Given this list of marker genes TSHZ2, MAP3K3, COL1A2, NPM3, MMP2, PTPN2, ULBP1, MEF2D, LIMD2, B3GALT2, ZNF654, RNF114, PER2, SCARF1, CERS6, AZIN2, RNF185, MED31, CRNKL1, LPAR1, IL17RE, RPL22, MAGED1, ARL1, CAMLG, NREP, UNC5C, EGLN3, SRPX2, THEM6, SLPI, TNFAIP2, NPEPPS, PCNX1, NCAM1, RASGRP2, REV1, ORM1, COL1A1, KRT79, PPP1R15A, LRMDA, CALB2, DNAJC4, CELA2A, FAM222B, ZFP37, TRIP10, CNIH2, CGGBP1, COL4A1, APOC2, SNCA, AQP9, IL12A, TEAD1, TMEM119, OASL, RIMKLA, FAM241B, ZCRB1, SRGAP1, P4HA2, COQ8A, TGFBI, GBP4, SDF4, SLC15A3, MRPL44, COL5A1, RPE, SLC2A3, OSM, RNF182, MMP9, SHISA9, ACHE, CPED1, BEX2, RNASET2, MAGED2 (MAGE family member D2), DDT, BRINP1, RBPJ, ERO1A, DDO, SAPCD2, SAA4, CRLF1, RO60, CSF3, CSF2, LRRIQ3, AMTN, BMAL2, UBL5 (NCBI Gene Id 59286), FYB1, CAMK2N1, ZBTB8OS, TMEM130, PPFIA3, RNF125, ANKRD37, CFAP210, SERPINE1, ATRNL1, KCNK10, ZFP36L1 (NCBI Gene Id 677), DTNA, ZNF264 (zinc finger protein 264), BAMBI, TBC1D12, KDM5B, MCFD2, DKK2, QPCT, FAM162A, WHAMM, SLCO1C1, ALDH1L2, NFKBIZ, RPS25, ZC3H18, RTRAF, CXCL6, H2AJ (H2A.J histone), PDPR, ADAM9, SRRM2, LUM, ZMIZ1, CH25H, ANKRD12, SMOX, VEGFA, NTAN1, CFP, HDAC9, HP, TNFSF14, C11orf71, AMMECR1L (AMMECR1 like), CLHC1, DCN, MAN1A1, FKBP7, MTDH, SCN4B, G3BP2, VPS36, LETM1, OMP, ERRFI1, ERGIC1, TNIP1, TMC7, SNAP29, COL23A1, ATP9A, SKIL, SLC27A4, EVC, AOAH, GREM2, FAM43A, LMF1, CEP44, PTGES, COX19, COL3A1, PRDM16-DT, TAOK3, IL4R, GYS1, SERPINB4, PPP1R1B, SLX4IP, DECR2, DMGDH, CD300LF, SLC1A2, DDIAS, ARPP19, CRCT1, PPBP, HEATR6, FCGR2B, PLBD1, CACNA1H, ANTXR1, LHCGR, PILRB, GCNT2, BST1, ECPAS, S100A8, SLC4A3, DNAJC12, PICALM, CX3CL1, here is a description of the gene set: studied in species Homo sapiens Genes down-regulated in CD8 T cells: healthy versus CLL (chronic lymphocytic leukemia). from publication Görgün G, Holderried TA, Zahrieh D, Neuberg D, Gribben JG (PMID 15965501) To examine the impact of tumors on the immune system, we compared global gene expression profiles of peripheral blood T cells from previously untreated patients with B cell chronic lymphocytic leukemia (CLL) with those from age-matched healthy donors. Although the cells analyzed were not part of the malignant clone, analysis revealed differentially expressed genes, mainly involved in cell differentiation in CD4 cells and defects in cytoskeleton formation, vesicle trafficking, and cytotoxicity in CD8 cells of the CLL patients. In coculture experiments using CLL cells and T cells from healthy allogeneic donors, similar defects developed in both CD4 and CD8 cells. These changes were induced only with direct contact and were not cytokine mediated. Identification of the specific pathways perturbed in the T cells of cancer-bearing patients will allow us to assess steps to repair these defects, which will likely be required to enhance antitumor immunity. Gene expression profiling was performed to determine whether CLL cells induce changes in T cells in patients with CLL. Human Gene Set: GSE8835_HEALTHY_VS_CLL_CD8_TCELL_DN